Given this list of marker genes MAPK1, PTK2B, MAPK3, NRAS, GRB2, RAF1, BRAF, MAP2K2, HRAS, KRAS, SOS1, ARAF, SRC, MAP2K1, SOS2, here is a description of the gene set: Human Gene Set: KEGG_MEDICUS_REFERENCE_CA2_PYK2_RAS_ERK_SIGNALING_PATHWAY studied in species Homo sapiens Ca2+-PYK2-RAS-ERK signaling pathway. Pathway ID: N00538. Pathway type: Reference. Pathway class: nt06526 MAPK signaling. Pathway Definition from KEGG: Ca2+ -> PTK2B -> SRC -> GRB2 -> SOS -> RAS -> RAF -> MEK -> ERK